Given this list of marker genes CD14, HERPUD1, CD53, SLC11A2, CDKN1A, HK2, CCL7, PDGFA, IL1A, JUNB, IFRD1, TARDBP, TBRG4, NAB1, ANGPTL4, JARID2, GTPBP4, OTUD5, TNFSF9, IL10, ILF3, NFKBIZ, TXNRD1, SRSF10, HNRNPH1, NSMCE1, EIF1AY, LPAR1, ADAM9, STARD7, RAB10, IL15, FNDC3A, MAP2K4, APAF1 (apoptotic peptidase activating factor 1), YTHDF3, CLEC4E, ID1, LTBP1, MARCHF7, NFKB2, RELB (RELB proto-oncogene, NF-kB subunit), LGALS4, KPNA3, SPATA13, BCL3, TAX1BP1, GLIPR2, MMP10, AGFG1, TLE3 (NCBI Gene Id 7090), FCGR2B, PROCR, EXT1, SNX10, SOWAHC, RHOQ, DCUN1D5, HSPA5, MYD88, ZNRF1, RIOK3, CCND2, RAB12, BHLHE40, B4GALT3, UGCG, CXCL9, PELI1, SLC12A7, MDM2, LDAF1, PLA2G4A, ACSL1, MARCKSL1, PPIC, CLCN5, MAPRE1, IL1RN, HSP90AA1, MMP13, STAT3, UTP4, LCN2, DLD (dihydrolipoamide dehydrogenase), TSR1, IL4R, MAP3K8, UBE2D3, RHOB, MRPL52, PTGS2, SELP, AASS, PSMA6, TANK, CCNL2, G3BP1, CPD, SCAMP1, GBP7, STAT5A, DNAAF10, EHD1, PLAUR (plasminogen activator, urokinase receptor), N4BP1, MTMR14, PLEKHA1, CD40, DPP6, MMP14, HUWE1, NFKBIB, MYADM, RNF19B, RNF103, ABRACL, KDM3A, HIF1A, PAK1IP1, IFNAR1, ATP13A3, KLF3, GPR3, TOP1, DDX3Y, MFSD14A, CLEC4D, TNFAIP2, CYFIP1, ICAM1, EIF6, EXOSC5, HNRNPK, SERPINB2, ACOD1, KDELR3, SLC30A4, LCP2, IL1B, IST1, AMBP, DUSP16, PTGES, NAB2, ZEB1, MCOLN2, PIAS2, MYC, CSNK1A1, SSX2IP, SOCS3, MED20, BIRC3, PHOX2A, KCMF1, RNF145, VCL, ST3GAL4, ERRFI1, CEBPD, NEK6, CTPS1, SH3GL1, NUPR1, VASP, ETS2, NOP58, SOCS1, SLC31A1, SERPINE1, JAK2, HIVEP1, LRRC58, PIM1, PBRM1, DUSP1, TES, CCL13, MMP12, CXCL2, SRGN, INPP5B (inositol polyphosphate-5-phosphatase B), CRKL, PDPN, STIP1, CA2, NFKB1, BCL2A1, GCH1, TRA2B, MTDH, MSR1, CR1L, RNF149 (ring finger protein 149), STK40, CEBPB, SERTAD1, IER2, MAP4K4, here is a description of the gene set: Genes down-regulated in T conv from: peripheral lymph nodes versus thymic precursors. studied in species Homo sapiens Human Gene Set: GSE42021_TCONV_PLN_VS_TREG_PRECURSORS_THYMUS_DN from publication Toker A, Engelbert D, Garg G, Polansky JK, Floess S, Miyao T, Baron U, Düber S, Geffers R, Giehr P, Schallenberg S, Kretschmer K, Olek S, Walter J, Weiss S, Hori S, Hamann A, Huehn J (PMID 23420886) We investigated at which stage of maturation commitment to a stable Foxp3-expressing phenotype takes place. We assessed stability of Foxp3 expression in thymic Foxp3+ Treg subsets of different maturity, defined by CD24 expression. Next we compared gene expression profiles of Foxp3+ Treg subsets (+) of different maturity (24lo, 24int, 24hi) and could identify a set of genes that were specifically up or downregulated in Foxp3+ Tregs, but not in Foxp3- conventional T cells, in a maturation-dependent manner.